Given this list of marker genes IL2RG, STAT1, IL7, JAK1, TSLP, JAK3, STAT5A (NCBI Gene Id 6776), IL7R, here is a description of the gene set: Human Gene Set: GOBP_INTERLEUKIN_7_MEDIATED_SIGNALING_PATHWAY The series of molecular signals initiated by interleukin-7 binding to its receptor on the surface of a cell, and ending with the regulation of a downstream cellular process, e.g. transcription. species: Homo sapiens